The following is a description of a gene set: Mouse Gene Set: REACTOME_SYNTHESIS_OF_PC species: Mus musculus Synthesis of PC, and this is the list of marker genes: Csnk2a2, Chat, Pctp, Cept1, Abhd3, Stard10, Lpin2, Stard7, Slc44a5, Slc44a2 (solute carrier family 44, member 2), Phospho1, Pcyt1a, Slc44a4, Chpt1, Chka, Pemt, Mfsd2a, Chkb, Slc44a3, Lpcat1, Lpin3, Csnk2b, Slc44a1, Csnk2a1, Pcyt1b